The following is a description of a gene set: Mouse Gene Set: TABULA_MURIS_SENIS_LARGE_INTESTINE_BRUSH_CELL_OF_EPITHELIUM_PROPER_OF_LARGE_INTESTINE_AGEING studied in species Mus musculus from publication Tabula Muris Consortium (PMID 32669714), and this is the list of marker genes: Ppp1r9a, Tle5, Gsn, Cfl1, Psmc1, Prr13, Erbin, Pkm, Ptms, Gfus, Jund, Nrgn, Clic4, Polr2a, Dnah7b, Rbm38 (NCBI Gene Id 56190), Rpl13a, Ubb-ps, Cnp, Banp